Given this list of marker genes AKT2 (NCBI Gene Id 208), PPP2R3B, AKT1, PPP2R3C, PPP2R5D, PPP2R5A, PPP2R2B, CD86, PPP2R3A, CTLA4, PPP2R2A, PPP2CA (NCBI Gene Id 5515), AKT3, CD80, PPP2R2D, PPP2R1A, PPP2R5B, PPP2R5E, PPP2CB, PPP2R1B, PPP2R5C, PPP2R2C, here is a description of the gene set: studied in species Homo sapiens Human Gene Set: KEGG_MEDICUS_REFERENCE_CD80_CD86_CTLA4_PP2A_SIGNALING_PATHWAY CD80/CD86-CTLA4-PP2A signaling pathway. Pathway ID: N01579. Pathway type: Reference. Pathway class: nt06530 PI3K signaling. Pathway Definition from KEGG: (CD80,CD86) -> CTLA4 -> PP2A -| AKT